The following is a description of a gene set: Mouse Gene Set: chr1A5 studied in species Mus musculus, and this is the list of marker genes: Gm24064, Gm26418, Gm9443, Tubb4b-ps2, Gm6473, Gm7761, B3gat2 (NCBI Gene Id 280645), Gm29214, Gm5525, Mir30c-2, Ogfrl1, Rims1, Gm24176, Gm6420, Ppp1r14bl, Spata31e5, Gm28822 (predicted gene 28822), Gm2914, Smap1, Gm5524, Gm7858, 2900022M07Rik, Gm7784, Gm19641, Lmbrd1, Gm18443, Gm20954, Col19a1, Mir6342, Gm7846, Col9a1 (NCBI Gene Id 12839), Gm6462, Fam135a, Gm10222, Gm20172, 2900002M20Rik, Gm29506, Gm18776, Gm29414, Gm25294, Gm5697, Adgrb3, Sdhaf4, Gm9898, Gm18033, Spata31e2, Gm26524, Gm19123, Atp6-ps, Gm19028, 8030445P17Rik (RIKEN cDNA 8030445P17 gene), Gm9884, Phf3, Mir30a